The following is a description of a gene set: Any of the long, generally straight, hollow tubes of internal diameter 12-15 nm and external diameter 24 nm found in a wide variety of eukaryotic cells; each consists (usually) of 13 protofilaments of polymeric tubulin, staggered in such a manner that the tubulin monomers are arranged in a helical pattern on the microtubular surface, and with the alpha/beta axes of the tubulin subunits parallel to the long axis of the tubule; exist in equilibrium with pool of tubulin monomers and can be rapidly assembled or disassembled in response to physiological stimuli; concerned with force generation, e.g. in the spindle. Mouse Gene Set: GOCC_MICROTUBULE species: Mus musculus, and this is the list of marker genes: Ttll10, Haus8, Kif11, Casp1, Pde4dip, Aurkb, Ccdc181, Reep3, Mtcl2, Dnah2, Gas2l1, Ska2 (NCBI Gene Id 97710), Tubgcp2, Saxo4, Tubb2a, Cyp2a5, Crhbp, Ror2, Mx2, Dctn2, Dnah17, Kif5b, Camsap1, Trip10, Akna, Svil, Klhl21, Tubb3, Efhc1, Csnk1d, Clip2, Ckap2, Tubd1, Reep1, Eml2, Chmp3, Rmdn1, Spag17, Tubgcp6, Rmdn3, Kif5a, Pycard, Marcks, Cep57, Tubgcp5, Arl6, Map1lc3a, Cct3, Tbca, Calm2, Haus7, Gabarap, Ttll3, Hdac6, Map1lc3b, Cul3, Tpgs2, Kif3b, Cfap68, Kif26a, Luzp1, Nek2, Stau2, Enkd1, Map7, Tppp2, Ttl, Sctr, Klc3, Spmip11, Camsap2, Calm1, Dst, Fez1, Grip1, Tcp11l1, Drd4, Cfap52, Dynlt2a1, Cct6a, Nckap5l, Tubb4b, Clip1, Rassf3, Dusp21, Serp1, Atat1, Radil, Tekt3 (tektin 3), Dnah1, Clip3, Cimap1d, Rgs14, Sybu, Cep295 (centrosomal protein 295), Tpt1, Map7d2, Tpgs1, Capn6, Chmp2b, Gtse1, Katnal1, Wdr47, Kifap3, Tppp, Kif22, Kif3c, Stim1, Kif3a, Ska1, Pierce2, Tubg2, Bcas3 (NCBI Gene Id 76344), Ift70a1, Nckap5, Map9 (microtubule-associated protein 9), Kif16b, Kifc3, Aurka, Rab3d (NCBI Gene Id 83761), Kif19b, Ribc2, Map1s, Srprb, Pierce1, Cfap90, Togaram1, Cspp1, Ninl, Cfap20, Sntb2, Hnrnpu, Map6d1, Arl3, Fsd1, Polb, Map1a, Nin, Nav3, Map2, Mapre3, Appbp2, Kif2a, Hsph1, Arhgap18, Kif9, Mapre2, Invs, Kif28, Cct8, Ndrg1, Calm3, Gabarapl1, Lrpprc, Reep4, Chmp4b, Igbp1, Wdr44, Kif19a, Tuba1c, Septin9, Pacrg, Iqgap1, Kif24, Trim54, Hook1, Klhl22, Tuba1a, Pbxip1, Klc4, Tubal3, Ttll13, Knstrn, Spef1, Cimip2c (NCBI Gene Id 75434), Aspm, Dcdc2b, Ino80, Kcnab2, Disc1 (NCBI Gene Id 640053), Fhdc1, Dctn1, Map4, Dynlt1b (NCBI Gene Id 21648), Tekt5, Mapre1, Slain2, Arhgap4, Ska3, Shroom2, Haus5, Chmp7, Dnai1, Slain1, Ttll7, Apoe (apolipoprotein E), Dyrk1a, Golga2, Spmip9, Tuba3a, Katnal2, Dnm3, Spmip5, Map10, Spag8, Dync1i1, Matcap1, Dnm1, Fam110c, Tube1, Kif21b, Kif18b (NCBI Gene Id 70218), Kifc1, Spmip10, Abraxas2, Gas8, Apc, Fbxw11, Tubb6, Bex6, Prc1, Slc8a3, Klc1, Fam161b, Cnp, Dvl1, Cfap161, Mta1 (NCBI Gene Id 116870), Dync2h1, Cfap126, Ift70a2, Katnb1, Tppp3, Zfp804a, Cfap96, Cfap210, Kif5c, Clip4, Chmp6, Kif27, Shroom3, Dnai7, Bod1, Tekt1, Cdk2ap2, Eml6, Cfap144, Rmdn2, Mdm1, Dcdc2c, Ccsap, Synj2, Kif15, Hook3, Septin2, Togaram2, Cep170b, Birc5, Mns1, Opa1, Dynll2, Tuba1b, Cct7, Dcxr (dicarbonyl L-xylulose reductase), Bysl, Kif2c, Chmp1b, Bin1, Spast, Eml3, Spag4, Mapt, Cdk5, Dynlrb1, Dcx, Cep57l1, Klc2, Clasp1, Aurkc, Map1b, Ndel1, Saxo2, Haus2, Tiam1, Clmp, Rcc2, Saa1, Ttll1, Dynlt3, Dynlrb2, Haus6, Arfgef2, Kif6, Cimip2a, Cct4, Cep170, Cltc, Spry2, Gramd2b, Dync1li2, Tubgcp4, Dpp9, Kif13a, Keg1, Kif1b, Tekt2, Cfap276, Dync2li1, Bcl10, Tmem214, Chmp4c, Cfap45, Spag6l, Kif14, Sirt2, Cyld, Daxx, Ttll6, Kif23, Kif4, Spaca9 (NCBI Gene Id 69987), Katna1, Cfap53, Ift70b, Trpv4, Cdk5rap3, Plk1, Cdk1, Kif21a, Dysf, Enkur, Kif17, Emd, Synj1, Hid1, Tpx2, Chmp5, Kntc1, Gsk3a, Kif26b (kinesin family member 26B), Tuba4a, Arhgef2, Tektip1, Zfp207, Bbln, Kif13b, Mid1ip1, Slc8a2, Eml1, Saxo1, Tuba8, Tubg1, Parp4, Kif1c, Rab11a, Dync1i2, Wdr90, Cep162, Cfap141, Ccdc57, Ckap5, Jakmip1, Ribc1, Tubb5, Fam110a, Gas2l3, Pafah1b1, Mtus2, Bex4, Kif18a, Cfap77, Nudc, Dnah12, Rusc1, Zw10, Ttll11, Macf1, Lzts2, Tubb2b (tubulin, beta 2B class IIB), Tubgcp3, Gsk3b, Dync1h1, Map6, Rassf1, Hook2 (hook microtubule tethering protein 2), Haus4, Spag5, Kifc2, Dlg1, Ttll4, Gas2l2, Fam161a, Tubb4a, Dnm1l, Kif20b, Dcdc2a, Nicn1, Tektl1, Mid2 (NCBI Gene Id 23947), Shroom1, Ptpn20, Hspa8, Cenpj, Kif7, Cct2, Kif1a, Cct5, Odf2, Numa1, Cstpp1 (NCBI Gene Id 99024), Tbcb, Dnai2, Spmip6, Bicd1, Cfap107, Dpysl2, Bcl2l11 (BCL2 like 11), Clasp2, Fign, Bag2, Lrrc49, Dnal1, Nme7, Cdk5rap2, Apc2, Whamm, Tekt4, Misp, Mtcl1, Baiap2, Dctn3, Kif20a, Reep2, Kifc5b, Eml4, Dnal4, Map3k11, Kif2b, Rnf4 (ring finger protein 4), Chmp2a, Efcab6, Sarm1, Efhb, Stmn1, Shtn1, Nav1, Dynll1, Camsap3, Mefv, Efhc2, Nusap1, Cimip2b, Ttll9, Psrc1, Snph, Mid1, Haus3, Dnah3, Chmp1a, Chmp1b2, Map2k2, Selenos, Ccdc66, Mt3, Eml5, Fkbp4, Rpgrip1l, Rassf5, Dync1li1, Ttll5, Fgf13, Ttll8, Map2k1, Kif12, Tubb1, Slc8a1, Eif3a (NCBI Gene Id 320318), Iqgap2, Spmip8, Cfap206, Haus1, Pcnt, Cyp2a4, Dnm2, Saa2, Dnah8, Nde1, Dnah5, Cfap95, Tcp1, Incenp, Cenpe